The following is a description of a gene set: T cells develop from progenitors that migrate from the bone marrow into the thymus. Thymocytes are subdivided roughly as being double negative (DN), double positive (DP), or single positive (SP), based on the expression of the CD4 and CD8 coreceptors. The DN stage is heterogeneous and can be subdivided into four distinct subsets in mice based on the expression of CD44 and CD25. In human, three distinct DN stages can be recognized: a CD34+CD38−CD1a− stage that represents the most immature thymic subset and the consecutive CD34+CD38+CD1a− and CD34+CD38+CD1a+ stages. Human DN thymocytes mature via an immature single positive (ISP CD4+) and a DP stage into CD4+ or CD8+ SP T cells that express functional T cell receptors (TCR) and that exit the thymus. In this study, gene expression was measured in each of these nine stages. from publication Dik WA, Pike-Overzet K, Weerkamp F, de Ridder D, de Haas EF, Baert MR, van der Spek P, Koster EE, Reinders MJ, van Dongen JJ, Langerak AW, Staal FJ (PMID 15928199) Genes down-regulated in thymocytes: double negative versus CD4 single positive. Human Gene Set: GSE22601_DOUBLE_NEGATIVE_VS_CD4_SINGLE_POSITIVE_THYMOCYTE_DN species: Homo sapiens, and this is the list of marker genes: STIP1 (stress induced phosphoprotein 1), SIPA1L1, SLC39A1, GNGT2, PPP1R12A, STAT3, VASP, VWA5A, HLX, SLC25A30, ENTR1, CYP11A1, NOL10 (NCBI Gene Id 80085), MON1A (MON1 homolog A, secretory trafficking associated), RAB1A, IL4R, ATP6V1H, IRAK4, MITD1, PDCL3, SECISBP2, ECM1, MRS2, SNAPC1, BCL6, ST3GAL4, TBRG4, GMPPB, VPS54, RBM12, SLCO4A1, MAPK11, CIC, PPP4R3B, FUBP1 (far upstream element binding protein 1), AXIN2, GLIPR2, MYC, PLEKHG2, YWHAB, GRB2, TMEM64, SANBR, UTP4, AFP, PDIA6, CEBPB, CNDP2, ULK2, STING1, SRSF6, CASTOR1, STAT2, IL17RA, KRI1, AP4S1, SQLE, PSEN1, LAMA5, PPM1H, FOXO1, MRPL36, IL2RA, YRDC (yrdC N6-threonylcarbamoyltransferase domain containing), FLVCR1, ARHGAP29, SLC35B1, HYPK, DHX29, UQCRB, UBE2E2, ISCU, TMEM176A, CAPN2, CD53, LDHA, GPM6B, LBP, PRDM1, MRPL51, ABHD17C, SLC2A1, VSIR, HSPH1, FTSJ1, ZNF467, HIF1A, HOPX, MXD1, SEMA7A, DPY19L3, GNPDA2, ZNF207, DNAH8, MCL1, RPS6KB1, ENTPD4, RAB4B, XPO1, PRKAR2A, RBM6, TLR1, CRNKL1, CSF1, ZFP36L1, CYB5A (NCBI Gene Id 1528), S100A6, CTSC, PSMD6, MCTP2, MAT2A, RINL, BCCIP, P2RY14, NAA15, POU2AF1, MMGT1, DGLUCY, CYBC1, NKG7, PARP14, KPNA2, GATA1, TOP1, AJUBA, NOP2, PSMA7, LPCAT3, GTF3C6, CLDND1, YWHAH, MAP3K8, PTPN1, ANKRD13A, APP, UBA3, KSR1, PITPNA, AIMP2, CYB561A3, STX11, IL27RA, CUL2, PSMA3, CCNL2, ATXN7L3B, MGRN1, TNFRSF8, BUD31, ATP2A2, BAZ1A, AOPEP, PFN1 (NCBI Gene Id 5216), EED, NEAT1, PPA1, ETV6, GRAMD4, SLC39A7, ARPC5L, NDRG3, RAB18, NISCH, MTCH2, PPAN, MYD88, AKIRIN1, TIPARP, WDR45B, SATB1, NUS1, PSMC5, SAMHD1, GDAP2, SCAF4, ADCY6, PDE12, INPP5B, TGFB3, SLC49A4, SEMA4A, CMPK1, TIMM8B, IDE, SOCS1, IFITM2, MINDY3, TCF7, EI24, CTSW, DNAJB11, MIDN, DNAJA1, SAMD9L, TRPM4, TOR2A, GPKOW, NUFIP2, TNS4, EIF1AY